Given this list of marker genes PRKCI, SRSF5, IRS2, MAPK3, HDAC5, SOS2, SIRT1, SERPINA12, BGLAP, SLC27A1, ALAS1, ERRFI1, GCLC, GPLD1, IGF1R, HMGCS2, PDK4, PDK2, PIK3R3, STXBP4, DENND4C, SESN3, TRIB3 (NCBI Gene Id 57761), SMARCC1, SOCS3, SLC2A4, USF1, MTOR, TRARG1 (NCBI Gene Id 286753), MSTN, PIP4K2C, MAPK1, PIK3C2A, ZDHHC7, PRKAA1, ECHDC3, INSIG1, NUCKS1, PAK1, PDE3B, NDEL1, HDAC9, WDTC1, RAB10, SLC27A4, FOXO1, INPP5K, VAMP2, SOCS7, SHC1, FOXC2, RAB8A, NCK1, YWHAG, KAT2B, ZBTB7B, STAT1, TSC2, MIR195, COL6A1, BAIAP2, PARP1, NCOA2, SLC22A12, PTPRE, GKAP1, G6PC1, DNAI1, CTSD, GHSR, PTPRJ, PTPN1, HRAS, FER, BCAR1, PKLR, SIK2, INS, EEF2K, MIR15B, C2CD5, SORL1, RAB13, EIF4EBP2, BLVRB, PTPN2, INSRR, PIP4K2B, PRKCD, PIK3CA, GHRHR, SELENOS, TRIM72, GHR (NCBI Gene Id 2690), CUL7, PCK2, PIK3R1, SORBS1, INSIG2, KANK1, GRB10, TNS2 (NCBI Gene Id 23371), ATP2B1, XBP1, CPEB2, APC, OSBPL8, IGFBP1, RHOQ, LPIN2, SOCS1, ERFE, ZNF106, FFAR3, AKT1, APPL2, SGCB, KBTBD2, MIR103A1, PIP4K2A, FUT7, MIR107, SLC9A1, PPARG, RARRES2, PKM, AKT2, SYAP1, RAF1, APPL1, CEACAM1, GPR21, SH2B2, ZNF592, PIK3R2, IDE, GSK3B, PCSK9, PCK1, GOT1, MTCL2, AP3S1, NCOA5, CPEB1, BCAR3, CSRP3, CAV2, ADIPOR1, SREBF1, LEP, NCOA1, RAB31, IRS1, PRKCQ, PRKDC, IGF1, NCL, MAPKAP1, IGF2, SOS1, INSR, C1QTNF12, VWA2, GRB14, GAB1, LONP1, GCK, LPIN3, FOXO4, ADIPOQ, RBX1 (NCBI Gene Id 9978), RELA, GRB7, MZB1, IL1B, PTPN11, CFLAR, POU4F2, NR1H4, INHBB, EPRS1, IRS4, PNPLA3, CAPN10, PHIP, SP1, SLC39A14, FBXW8, SLC25A33, UCP2, SRD5A1, RPS6KB2, TBC1D4, RPS6KB1, FBP1, NAMPT, ENPP1, MYO1C, PID1, OTOP1, RBM4, SLC2A8, PRKCB, CUL3, GSTP1, PDPK1, LPIN1, RB1, PLA2G1B, GSK3A, OGT, MYO5A, PRKCZ, AHSG, USO1, GRB2, SNX5, MIR1271, ZFP36L1, here is a description of the gene set: Human Gene Set: GOBP_CELLULAR_RESPONSE_TO_INSULIN_STIMULUS Any process that results in a change in state or activity of a cell (in terms of movement, secretion, enzyme production, gene expression, etc.) as a result of an insulin stimulus. Insulin is a polypeptide hormone produced by the islets of Langerhans of the pancreas in mammals, and by the homologous organs of other organisms. studied in species Homo sapiens